Given this list of marker genes Ncan, Prb1b, Efs, Gsap, Osbpl7, Pole (NCBI Gene Id 18973), Zc3h12d, Grk4, Pramex1, Sybu, Opalin, Clec3a, Cstf2, Gm4513, Atad3a, Relch, Dennd5a, Rnf4 (NCBI Gene Id 19822), Eif4b, Gm4567, Col27a1, D630045J12Rik, Pcna, Krtap4-6, Snx27, Grin2c, Cntnap2, Zfp563, Gm6902, Acp2, Slc25a40, Adamts9, Zfp748, Nutf2, Cdh7, Nr5a2, Rnf44, Usp27x, Cilk1, Lcn8, Cbfa2t3, Meiob, Nags, Hoxa5, Mfap3l, Gid4, Ythdf1, Tbl1x, Slc7a7, Gm4565, Dlx1, Arpp21, Sntb2, Elmod2, Greb1l, Gfra2, here is a description of the gene set: from publication Chen Y, Wang X (PMID 31504780) species: Mus musculus Mouse Gene Set: MIR_3057_5P Genes predicted to be targets of miRBase v22 microRNA mmu_miR_3057_5p in miRDB v6.0 with MirTarget v4 prediction scores > 80 (high confidence targets).